Given this list of marker genes Gtf2h4, Polr2k, Ctr9 (NCBI Gene Id 22083), Gtf2f1, Supt5, Leo1, Eaf1, Nelfa (negative elongation factor complex member A, Whsc2), Nelfe, Polr2b, Gtf2h2, Ccnh, Gtf2f2, Ercc3, Polr2e, Tcea1, Polr2f, Eaf2, Mllt1, Polr2i, Ctdp1, Supt16, Supt4a, Iws1, Ercc2, Polr2a, Polr2c, Polr2l, Aff4, here is a description of the gene set: part of: RNA Polymerase II Transcription studied in species Mus musculus This event has been computationally inferred from an event that has been demonstrated in another species.<p>The inference is based on the homology mapping from PANTHER. Briefly, reactions for which all involved PhysicalEntities (in input, output and catalyst) have a mapped orthologue/paralogue (for complexes at least 75% of components must have a mapping) are inferred to the other species. Reactome Pathway: RNA Polymerase II Transcription Elongation electronically inferred by orthology from the curated human pathway